Given this list of marker genes Cacng4 (calcium channel, voltage-dependent, gamma subunit 4), Cacng7, Cacnb1, Kcne5, Cacna2d2, here is a description of the gene set: part of: Cardiac conduction electronically inferred by orthology from the curated human pathway studied in species Mus musculus This event has been computationally inferred from an event that has been demonstrated in another species.<p>The inference is based on the homology mapping from PANTHER. Briefly, reactions for which all involved PhysicalEntities (in input, output and catalyst) have a mapped orthologue/paralogue (for complexes at least 75% of components must have a mapping) are inferred to the other species. Reactome Pathway: Phase 2 - plateau phase